The following is a description of a gene set: Human Gene Set: GSE12392_CD8A_POS_VS_NEG_SPLEEN_DC_UP Type I Interferons encompasses a large family of closely related cytokines comprising of at least 13 IFN-α isotypes and single IFN-β. Both IFN-α and IFN-β exert their activity through a common receptor IFNAR. Type I Interferons have broad regulatory effects and various subtypes of dendritic cells are influenced by this cytokines. In our study we asked question whether the low, constitutive levels of type I Interferons produced under steady state conditions are important for proper function of splenic conventional dendritic cells. from publication Zietara N, Łyszkiewicz M, Gekara N, Puchałka J, Dos Santos VA, Hunt CR, Pandita TK, Lienenklaus S, Weiss S (PMID 19581626) species: Homo sapiens Genes up-regulated in wildtype splenic dendritic cells: CD8A+ versus CD8A-., and this is the list of marker genes: PRKCD, SLC7A2, RPS6KA2, SLC35A2, COPS4, KPNA1, ANKRD49, TRIM25, RASGRF1 (NCBI Gene Id 9983), ZSCAN21, TBC1D23, IL12A, APRT, STX4, S1PR2, SULT2B1, ADORA2B, DSC1, CACHD1, ACP5, RAB10, CLCN7, ALDOA, CNP, TCIRG1, PRDX1, ANXA4, PTGES, NRBP1, SGPL1, MVD, ATG5, SPSB1, PDE1C, MMP12, EEA1 (NCBI Gene Id 8411, early endosome antigen 1), AGL, PTK7, RBPJ, AHCYL1, CARD19, VPS26A, CENPB, PSMA1, MOCS2, CDADC1, POU2F3, FMNL3, GBE1, ID2, KCNN4, NTRK3, PON3, SHBG, CACNB3, TOR3A, GALT, KIAA1191 (KIAA1191), AK2, CAPG, GSTA3, CCR7, OLR1, GOLPH3L, CD200, TRIM13, BABAM2, RPS6KB1, NCOA6, SACM1L, PTEN, CXCL14 (NCBI Gene Id 9547), CDC73, CHST3, CEP89, CRCP, SURF4, GHRL, TAMM41, SRA1, PRDX5, HAX1, CBFA2T2, CDK18, GPX4, ESD, BCHE, TMEM199, SLC34A2, C3, NPEPPS, PI4KA, PPP1R2P1, NINJ1, NQO1, HTATIP2, DNMT1, FGF14, ITK, TAP1, NDUFA1, ALAS1, DDT, TNNC1, ZC3H12C, IK, COPS2, ASS1, DNAJB2, DNAJB5, PPP3CC, TUBGCP4, ASF1A, ARG1, GPR162, FNDC3A, SLC4A4, TCEA1, STX12, ARL1, GPX2, ABCC1, NDUFAF1, GNRHR, TAPBP (TAP binding protein), HP, VPS26C, VPS25, MNAT1, C5orf15, RASAL1, KIF1B, SUSD6, ANAPC2, SERAC1, NODAL, RPL31, PGM1, COL10A1 (collagen type X alpha 1 chain), PLEKHA1, GSTZ1, PTGR1, PSMB5, IRF1, ERO1A, PITPNB (NCBI Gene Id 23760), CD38, SLC22A4, STXBP2, IDNK, CPNE6, ARFGEF1, SYNGR1, RANBP9, GLOD4, DNAJA2, BLOC1S1 (biogenesis of lysosomal organelles complex 1 subunit 1), TMEM168 (NCBI Gene Id 64418), SERF1A, ST6GALNAC1, PPP2R1A, RIOK1, ZNF639, THAP4, FBXW11, MSMO1, AVPR2, DDX46, TXNDC17, SCG2, NOS2, IREB2, PRDM1, MOB1B, UBR7, GPR132, NKAIN1, FABP7, UBR4, FZD8, STXBP3, DLD, RBKS, NUP88, SEL1L, AGXT, AGTRAP, BLTP3A, FBXO6, CTF1 (cardiotrophin 1), SMAP1, USP25, CYBB, TXNRD1, COASY, ADGRB1, CASP9, ABCC5, DERL2, LGALS3